The following is a description of a gene set: from publication Longo NS, Lugar PL, Yavuz S, Zhang W, Krijger PH, Russ DE, Jima DD, Dave SS, Grammer AC, Lipsky PE (PMID 19023113) studied in species Homo sapiens Genes up-regulated in plasma cells versus naive B cells. Human Gene Set: GSE12366_PLASMA_CELL_VS_NAIVE_BCELL_UP Sorted B cells using flow cytometry. CD19 selected B cells were sorted using flow cytometry., and this is the list of marker genes: MAGEF1, MTUS2-AS1, PARP4, HTR4, TEKTL1, GGH, PACSIN1, RNGTT, KNDC1, MAFB, NDUFB4, MYOM3, SLC10A7, MTFR1, MORF4L2, ALG5, MEGF8, TMEM132A, TMED9, SDHA, ISG20, GPX3, GRAMD2A, PTAFR, H2BC12L, ARFGAP3, EXT1, CIDEA, CGREF1, RTEL1, MAGT1, SH3D21, TNFRSF17, CCPG1, EME1, PRDX4, EAF2, SLC39A7, TIFA, RLN3, CNPY2, ROBO3, ALG2, MIR22HG, C11orf86, MCEE, TMEM39A, PQBP1, ZNF608, IDH2, LMAN1, SLC12A1, RABAC1, CYTIP, BCL2L11, H2BC5, GSTP1, COPB2, SELENOM, TCEAL9, SFTA2 (surfactant associated 2), EDEM3, ADGRA3, SEC23B, FENDRR, SEC24A (NCBI Gene Id 10802), PRKCI, RGS2, ZNF664, ADA, SGK3, RETSAT, TMT1A, DENND6B, CST3, LINC03011, EIF2S2, AAMP, SLC45A4, FZD3, FAM8A1, APBA2, ENSG00000284691, SLC35B1, RTL8C, CCL25, CDR2, SPCS1, TSNARE1, RAB2B, CCNC, GARIN5A, MGST2, ALG14, DENND1B, COPZ2, RPN2, CFAP54, ITFG2, MAP2, LINC00293, C2orf88, HBS1L, PIGK (NCBI Gene Id 10026), ZFAND4, ZDHHC8BP, TM9SF2, MROH1, TPP2, NDUFA4L2, MAST2, LYSMD3, SDE2, RANBP9, SLC1A4, GLCCI1, TP53I3, STARD5 (NCBI Gene Id 80765), YIPF1, AK3, CHST12, UNC50, POU4F1, RDX, CALML6, PCED1B-AS1, AGXT, CREBL2, TSPAN4, IRF4, NUPR1, TOM1L2, CYB561, WDR45, IL17RB, SEC14L1, NTNG2, IGLV4-3, ERO1B, KNTC1, MPST, CDRT4, CXXC4 (NCBI Gene Id 80319), TENT5C, HMGN3, OSTC, RAB5A, NRBF2 (nuclear receptor binding factor 2), TRPM4, SYNE2, PRDM15, TMEM91, ANKRD65, AACS (NCBI Gene Id 65985), HID1, SPCS3, EMX1, IGF1, TRAPPC3, H2BC6, LIME1, PRRC1, ITM2C, OSBPL3, UBXN10, TMEM179, MORC4, RGCC, MRPS31, DIO3OS, ST6GALNAC4, RHPN1, WSCD1, EDRF1, ABCC8 (ATP binding cassette subfamily C member 8), UBA5, CCDC14, ZKSCAN2, SEMA3C, SEC61G, DAPK3, CCDC88A, GEMIN7, ERGIC3, ISYNA1, FBXL16, HYI, LMNA, SSR2, ABHD8, BTG2, OCEL1, IGKV3-20, RPS27L, GOLPH3L